Given this list of marker genes CEP85, MT-TP (NCBI Gene Id 4571), TIMM8A, MIR34AHG, MT-RNR2, ISY1, CPEB4, MT-RNR1, MTND6P3, MT-TV, RAB14, GPSM3, MTCO1P12, SLC3A2, RAB5B, NCOA1, PMEL, SASS6, DUSP6, PTGS2, TPR, DNAJB4, MTCYBP18, PACERR, S100B, INTS4, CCL5, PPIL3, USO1, GCDH, TERT, TBX3 (NCBI Gene Id 91834), TRMT13, MTCO3P12, RN7SL181P, ELAVL4, NAV1 (NCBI Gene Id 89796), GARS1, IL10, MTCYBP35, NIF3L1, DARS2, MTND6P4 (NCBI Gene Id 106478943), CCNB1IP1, TCP1 (NCBI Gene Id 6950), CACYBP, EEF1A1, SUGT1, PDAP1, ISY1-RAB43, GGCX, GIPC2, ODR4, ACBD6, MRPL33, BUD31, CCDC14, GCNT3, ERCC1, RPL7, TIGD4 (tigger transposable element derived 4), MT-TF, ESR1, MRPL18, CENPL (NCBI Gene Id 91687), here is a description of the gene set: from publication Yevshin I, Sharipov R, Kolmykov S, Kondrakhin Y, Kolpakov F (PMID 30445619) Genes containing one or more binding sites for (HOXC11) in their promoter regions (TSS -1000,+100 bp) as identified by GTRD version 20.06 ChIP-seq harmonization. species: Homo sapiens Human Gene Set: HOXC11_TARGET_GENES